The following is a description of a gene set: Any process that stops, prevents or reduces the frequency, rate or extent of double-strand break repair via nonhomologous end joining. Human Gene Set: GOBP_NEGATIVE_REGULATION_OF_DOUBLE_STRAND_BREAK_REPAIR_VIA_NONHOMOLOGOUS_END_JOINING studied in species Homo sapiens, and this is the list of marker genes: AUNIP, TFIP11, CYREN (cell cycle regulator of NHEJ), HMGA2, ERCC6, MRE11, HSF1, NUDT16L1